Given this list of marker genes SPOP (speckle type BTB/POZ protein), PPFIA2, TAL1, SYT8 (NCBI Gene Id 90019, synaptotagmin 8), USP6, TRHDE, KAT6A, STK3, PFN2, TNRC6B, TRIM2, FOXN3, ANKRD54, ZNF800, CDK19, CADM2, ZC3H10, QKI, HLF, KLHL3 (NCBI Gene Id 26249), PCDHA5, HAPSTR1, KIAA2013, STMN4, PITPNM2, RHOC, UBAP1, FRMD4A, FOXK2, CAMTA1, PCDHA12, PCDHA3, PCDHA10, ITPKC, JOSD1, BAHD1, RSBN1, BAGE2, SMAD2, FNDC3B, PCDHA9, PPME1, TSC22D2, MAP3K11, PURB (NCBI Gene Id 5814), IZUMO4, DTNA, SGSM2, TMEM266, PCDHA7, ZFP91, PTBP2, USP47, RSBN1L, NIT1, MBNL2, RNF38, LPCAT3, DAZAP2 (NCBI Gene Id 9802), PCNX2, UBL3, ARHGEF10, PCDHA2, ATXN1, GIGYF1, SYNDIG1, ADAMTS5, COL23A1, ATP2B2, MAP2K4, PCDHA6, GSKIP, RTN4RL1, KMT2A, LSM14A, ESRP2, PRRX1, XIAP, ETV1, PCDHAC2, NEO1, DOCK3, HIC2, PDIK1L (NCBI Gene Id 149420), SEPTIN6, GAS2L1, CCDC6, RARG, ALX4, PCDHA4, ATXN7, ZNF24, MYT1L, PPP2R5E, C2orf42, OGA, PPP1R14D, PCDHA13, KCNRG, TUSC2, CORO1C, FNBP1L, EPHA8, IP6K1, PTPN4, PTPRT, ARHGEF3, C1orf21, ANKRD13C, TNKS2, PPP3CA, TFDP2, MBNL1, NFIB, YOD1, ZFR, GRM7, PCDHAC1, VEZF1, SLC2A4, HCN4, USP46, CCKBR, MLLT6 (MLLT6, PHD finger containing), ACTG1, BHLHE41, LINC00955, PCDH10, MRPS25, SEMA5B, PARP8, MAT2A, ACER3, KMT2C, TP53INP1, PCDHA11, TRIM3, SGMS1, NTNG1, DNAJA3, PPP1R11, PCDHA1, TP53INP2, PCDHA8, ZDHHC16, DHX40, TLN1, RETREG2, ZDHHC9, PLEKHM1, MARCHF8, FEM1C, LEF1, NSD3, here is a description of the gene set: Genes having at least one occurence of the motif CAGCACT in their 3' untranslated region. The motif represents putative target (that is, seed match) of human mature miRNA hsa-miR-512-3p (v7.1 miRBase). studied in species Homo sapiens Human Gene Set: CAGCACT_MIR5123P